Given this list of marker genes PTGES3, GPSM3, EEF1B2, SPN, SRSF2, DHX9, PFN1, TAF9, HNRNPD, VAMP7, SMARCC1, ARHGEF1, PCBP1, ARHGDIB, MAPRE1, DDX5, DRAP1, RHOA, MSN, YWHAZ, SF1, ABCC1, HNRNPL, PSME1, ARHGAP4, HMGN1, SET, TRAM1, here is a description of the gene set: Human Gene Set: GCM_MSN Neighborhood of MSN Neighborhood of MSN moesin in the GCM expression compendium studied in species Homo sapiens